Given this list of marker genes Tspan17, Ntan1, Sub1, Arhgdia, Selenow, Fuca1, Gsn, Cav1, Oaz2, Atp5me, Akt1, Elob, Sh3glb2, Ybx1, Nherf2, BC031181, Nop10, Ctnnb1, Mrps33 (mitochondrial ribosomal protein S33), Acer2, Polr2k, Jund, Ppia, Icam2, H2ac18, Ubxn1, Atp5f1e, Atf3, Kctd17, Dctn3, Ssbp4, Etfb, Slirp, Afdn, Cuta, Ssu72, Rps27l, Mlf2, Meox2, Atp5mj, Tpst1, Commd1, Klf4, Rsu1, Slc48a1, Mettl9, Rap1a, Lrp5, Fam174a, Rabac1, Coro1b (coronin, actin binding protein 1B), Mrpl4, Lsm5, Vps29 (NCBI Gene Id 80410), Sypl1, Ndufb4, Adam10, Rnf187, Cyb5a, Naa38, Ppp1ca, Klf13, Atp5mf, Pltp, Yif1b, Gtf2a2, Selenot, Dync1i2 (dynein cytoplasmic 1 intermediate chain 2), Nedd4, Tmem109, Ppp4c, Cracr2b, Banf1 (NCBI Gene Id 98145), Dynlt3 (dynein light chain Tctex-type 3), Ndufb5, Nicol1, Pdia3, Laptm4a, Nenf, Adipor1, Ets2, Rpn2, Cd151, Fth1, H2bc4, Selenop, Mrpl23, Cnpy2, Lgals1, Cavin1, Ndufa3, Palmd, Fis1, Elk3, Esam, Sem1, Lsm7, Cyfip1, Hrct1, Dusp3, Phb2, Cyc1, Sparcl1, Prelid1, H1f0, Fosb, Fmo1, Arap3, Adh5, Tm2d1, Romo1, Uqcc2, Myo1c, Rexo2, Ly6e, Cox17, Pet100, Klf2, Ppp2r5a (NCBI Gene Id 226849), Cox6b1, Ndufc2, Srsf5, Pfn1, Atp5pf, Cdkn1a, Erp44, Egr1, Mef2c, Ndufa4, Atp5if1, Podxl (podocalyxin-like), Uqcr11, Coa3 (cytochrome C oxidase assembly factor 3), Ost4, Anapc11, Fabp5, Tomm6, Mapk3, Tram1, Dnaja1, Spcs1, Pigp, Cenpx, Vps28, Gpx3, Tmed10 (NCBI Gene Id 68581), Tmem59, Rnf13, Scarb1, Lamp1, Ddost, Ctnnbip1, Sumo2, Hmgb2, App, Cirbp, Emc4, Itm2b, Bax, Mtarc2, Midn, Gnai2, Cyp2d22, Adam15, Hip1, Ablim3, Kank3, Akr1a1, Scn1b, Vapb, Ostc, Dph3 (diphthamine biosynthesis 3), Bnip3l, Tprg1l, Apold1, Apoe, Rnf130, Ndufa8, Cxcl14, Polr2g, Atp5mc2, Hint1, Fryl, Irf1, Ndufb9, Ei24, Dpm3, Ralbp1, Cd34, Psmc1, Rflnb, Anxa11, Ace, Flna, Ushbp1, Serf2, Uqcrq, Cdk2ap2, Arpp19, Comt, Ndufa7 (NCBI Gene Id 66416), Snrk, Aplp2, Sfn, Uqcrb, Rheb, Lamb2, Gna11, Tgfbr3, Lman1, Tspo, Lamtor2, Sumo3, Aplnr (apelin receptor), Rnf10, Ndufs6, Chchd7, Tob1, Capg, Gstm1 (glutathione S-transferase, mu 1), Acaa2, Polr2f, Nrp1 (neuropilin 1), Gpx4, Brk1, Rbm3, Atp6v0e, Spcs3, Timm13, Cope, D8Ertd738e, Gpihbp1, Mrpl42, Dazap2, Gstp1, Smim14, Ndufs3, 0610010K14Rik, Mtch1, Lmo1, Arpc4, Pbrm1, Pcp4l1, Ppdpf, Fmc1, Ndufb3, Rras, Grcc10, Eid1, Cfl1, Cd300lg, Sdha, Hmgb1, Vkorc1, Jup, Capns1, Rassf3, Bag1, Psma1, Iscu, Grn, Atp6v0b, Krtcap2, Smpdl3a, Park7, Acly, Prss23, Fli1, Gnas, Psmb9, Sdhc, Tns1 (tensin 1), Pam, Swi5, Zfp36, Plscr3, Rab11b, Cox6a1, Reep5, Spag7, Plaat3, Ndufa9, Ndufv2, Ech1, Ramp2, Hypk, Fus, Ptprm, Dnajc3, Psmc3, Ndufs8 (NCBI Gene Id 225887), Cd2ap (CD2-associated protein), Sh3bp5, Fbln5, Mrps14, Mrps18c, Ndufc1, Psmb3, Tsen34, Cmpk1, S100a16, AW112010, Ndufb7, Churc1, Tspan15, Mtln, Bcam, Sh3bgrl3, Snf8, Irf8, St6galnac2 (NCBI Gene Id 20446), Slc25a4, Cd59a, Ptpra, Higd2a, Nisch, Cd47, Rer1, Bloc1s1, Yipf4, Rbm42, Prdx4, Tmco1, Aqp1, Cops9, Rtl8b, Cox4i1, Egfl7, Vamp8 (NCBI Gene Id 22320), Ctsz, Rnaseh2c (ribonuclease H2, subunit C), Dda1, Ppp1r11, Drap1, Mpzl1, Sri, Aqp7, Cfdp1, Eml1, Atp5po, Tcf3, Fn1, Tnfsf12, Cetn3, Atp5mg, Btg2, Rbx1, Ablim1, Qdpr, Ndufb2, Adgrl4, Mff, Ccnd3, Atp5f1c, Epas1 (NCBI Gene Id 13819), Sncg, Mrpl54, Lman2, Atp6v1g1, Ttc28, S100a1 (NCBI Gene Id 99575), Hspg2, Fkbp3, Srp14, Anapc13, Aldh2, Bsg, Ndufv3, Edf1, Ypel3, Chmp5, Pdia6, Gimap4, Sptbn1, Stk25, Sgms1, Ehd2, Ccdc124, Tspan13, Vat1, Ddrgk1, Oaz1, Atox1, Uqcrc1 (NCBI Gene Id 66186), Chmp3, Myl12b, Ifngr1, Pgls, Slc50a1, Guk1, Gda, Ly6a, Sptssa, Tmem147, Timp4, Ctbp1, Fcgrt, Pabpn1, Anxa5, Sult1a1, Ndufa11, Snrnp27, Smagp, Spr, Hnrnpa0, Acat1, Gtf2h5, Cavin2, Uqcrfs1, S100a6, Lmcd1, H2az2, Ly6c1, Ube2b, Mrpl20, Igfbp6, Selenom, Ubl5, Ltbp4, Zyx, Crip2, Cops6 (COP9 signalosome subunit 6), Immp1l, Dock9, Sptan1, Cldn15, Ywhah, Fbln2, Clptm1, Psmb10, Myadm, Dram2, Smco4, Tex261, Ndufa6, Dnajc19, Ndufv1, Wdr83os, Socs3, Psap, Igfbp4, Cyba, Mrps21, Ndufb10, Ptprb, Pink1, Ndufa2, Tmem134, C130074G19Rik, Tle5, Ndufs7, Mylk, Smim11, Smad1, Jam2, Spcs2, Myl6, Chmp2a, Vamp5, Ndufa13, Sec13, Syf2, Pnkd, Tmem30a, Timp3, Spint2, Sec14l1, Amfr, Arpc3 (actin related protein 2/3 complex, subunit 3), Ostf1, Cxcl12, Cav2 (caveolin 2), Tmem160, Adamts1, Trappc6b, Car4, Trp53i11, Slc29a1, Prdx2, Snhg3, Anp32a, Ccnd2, Gnb2, C1qtnf9, Ssr4, Sf3b2, Cavin3, Mgll, Sdhb, Atraid, Ndufa5, Tmem256, Rtl8a, Bola3, Tspan7, Dpysl2, Ddx5, Pea15a, Gng11, Abhd17a, Cst3, Cnn2, Gstt2, Calm3, Tmem50a, Zc3h12a, Smdt1, Rps28, Pde2a, Crim1, Scp2, Cd81, Ptms, Mrpl14, Uqcr10, Cyb5r3, Ddit3, Mgst1, Emc10, Nectin2, Micos13, Stmn2, Ppib, Epn1, Sec11c, Lims2, Tmed3, Ndufb8 (NADH:ubiquinone oxidoreductase subunit B8), Kdelr1, Fos, Nedd8, here is a description of the gene set: studied in species Mus musculus Mouse Gene Set: TABULA_MURIS_SENIS_MAMMARY_GLAND_ENDOTHELIAL_CELL_AGEING from publication Tabula Muris Consortium (PMID 32669714)